The following is a description of a gene set: Any process that stops, prevents or reduces the frequency, rate or extent of bone development. Mouse Gene Set: GOBP_NEGATIVE_REGULATION_OF_BONE_DEVELOPMENT species: Mus musculus, and this is the list of marker genes: Rgn, Dspp, Bglap, Ggcx, Bglap2